The following is a description of a gene set: studied in species Mus musculus Mouse Gene Set: GOBP_FAT_SOLUBLE_VITAMIN_METABOLIC_PROCESS The chemical reactions and pathways involving of any of a diverse group of vitamins that are soluble in organic solvents and relatively insoluble in water., and this is the list of marker genes: Ttpa, Lipa, Nfkb1, Cyp4f40, Pltp, Dgat1, Fgf23, Ggcx, Sp1, Strap, Aifm2, Cyp27a1 (cytochrome P450, family 27, subfamily a, polypeptide 1), Cyp27b1, Cyp26c1, Cbr1b, Vkorc1l1, Cyp2w1, Klf9, Cyp24a1, Lrp2, Fgfr4, Ubiad1, Isx, Snai2, Gc, Cyp2r1, Nqo1, Enpp1, Vkorc1, Gfi1, Fgfr1, Cbr1, Snai1, Npc1l1, Cbr3, Cyp26a1, Rbp1, Lrat, Ifng, Cyp26b1, Tnf